The following is a description of a gene set: Mouse Gene Set: MIR_5104B_5P from publication Chen Y, Wang X (PMID 31504780) species: Mus musculus Genes predicted to be targets of miRBase v22 microRNA mmu_miR_5104b_5p in miRDB v6.0 with MirTarget v4 prediction scores > 80 (high confidence targets)., and this is the list of marker genes: Wdfy3, Lix1, Ephb2, Phyhip, Ankrd9, Gvin1, Kif3c, Slc8a1, Trim12a, Gsk3b, Gm21379, Sfpq, Itsn1, Crim1, Lrit1, Jade1, Iqsec2, Gvin2, Slc44a1, Tmie, Rpl21, Myom3, Pars2, Fgf1, Akr1d1, Gpr141, Ubl4b, Rbm31y, Ero1b, Cnnm3, Ccdc71l, Tln2, Capn8, Cdt1, Lrrc56, Tcp11x2, Dennd5a